The following is a description of a gene set: Increased corneal thickness Human Gene Set: HP_INCREASED_CORNEAL_THICKNESS A increased anteroposterior thickness of the cornea. species: Homo sapiens, and this is the list of marker genes: FGFR3, FGFR2, DCN, FGF10, SLC4A11